Given this list of marker genes KIF22, TRAPPC2, COL11A2, MATN3, COL1A1, SLC26A2 (solute carrier family 26 member 2), FBN1, ACAN, DDRGK1, TRPV4, here is a description of the gene set: species: Homo sapiens Human Gene Set: HP_PREMATURE_OSTEOARTHRITIS Premature osteoarthritis